The following is a description of a gene set: The process in which the anatomical structure of cardiac atrium muscle is generated and organized. Mouse Gene Set: GOBP_ATRIAL_CARDIAC_MUSCLE_TISSUE_MORPHOGENESIS species: Mus musculus, and this is the list of marker genes: Bmp10, Wnt2, Prox1, Tnnt2, Nog, Eng, Myh6, Pitx2